Given this list of marker genes EIF2S3B (eukaryotic translation initiation factor 2 subunit gamma B), EIF2S2, EIF2S1, EIF2A, EIF2S3, here is a description of the gene set: Human Gene Set: GOCC_EUKARYOTIC_TRANSLATION_INITIATION_FACTOR_2_COMPLEX studied in species Homo sapiens Complex of three heterogeneous polypeptide chains, that form a ternary complex with initiator methionyl-tRNA and GTP. This ternary complex binds to free 40S subunit, which subsequently binds the 5' end of mRNA.